Given this list of marker genes Acsl1, Cebpa, Nr1h3, Adrb3 (NCBI Gene Id 11556), Aoc3, Dgat1, Pcx (NCBI Gene Id 18563), Fabp4, Scd1, Adipoq, Lipe, Pparg, Agt (angiotensinogen), Fasn, Cfd, Gpd2, Retn, Nr1h2, here is a description of the gene set: The PPARgamma is a key adipogenic determination factor. Ligands for PPARgamma such as antidiabetic thiazolidinedione (TZD) compounds are adipogenic, and many adipocyte genes that are activated by TZDs contain binding sites for PPARgamma. Like ligands for other nuclear receptors, TZDs can regulate genes positively or negatively. Here, we sought to understand the importance of positive regulation of gene expression by PPARgamma in adipogenesis. Fusion of the potent viral transcriptional activator VP16 to PPARgamma2 (VP16-PPARgamma) created a transcription factor that constitutively and dramatically activated transcription of PPARgamma-responsive genes in the absence of ligand. Forced expression of VP16-PPARgamma in 3T3-L1 preadipocytes using retroviral vectors led to adipogenesis in the absence of standard differentiating medium or any exogenous PPARgamma ligand. Gene microarray analysis revealed that VP16-PPARgamma induced many of the genes associated with adipogenesis and adipocyte function. Thus, direct up-regulation of gene expression by PPARgamma is sufficient for adipogenesis. TZD-induced adipogenesis up-regulated many of the same genes, although some were divergently regulated, including resistin, whose gene expression was reduced inVP16-PPARgamma adipocytes treated with TZDs. These results show that, although activation of PPARgamma by a heterologous activation domain is sufficient for adipogenesis, it is not equivalent to TZD treatment. This conclusion has important implications for understanding biological effects of the TZDs on adipogenesis and insulin sensitization. from publication Li Y, Lazar MA (PMID 11981038) species: Mus musculus Mouse Gene Set: LI_ADIPOGENESIS_BY_ACTIVATED_PPARG Adipocyte genes induced in 3T3-L1 cells (adipocyte) by constitutively active PPARG or its agonist, TZD.